Given this list of marker genes VPS11, INPP5E, LYST, PDE4DIP, ECE2, GRIK5, PHACTR4, NAA10, TAF4B, SLC9A7, TRAF2, UCK2, UBXN7, HSPE1, ARSA, APOBEC3B, TTPA, HOMER3, PRKAR1B, PEX6, CEBPE, POLR2H, OGT, RAB32, TUG1, GRAMD4, CALCR, BST1, GTF2H3, TPM2, TSPO, SLC22A4, PRLR, ATP6V0B, BRD8, PMS2P3, TKT, VAT1, KIF2A, ATF2, GPR3 (G protein-coupled receptor 3), GABARAP, WT1-AS, HARS2, AZU1, BCAT1, ATF6B, HADH, TIA1 (TIA1 cytotoxic granule associated RNA binding protein), XPO1, ZYX, APLP2, GPR182, GTF2F2, TLL1, OVOL2, TTC22, TAF1, ENSA, HNF4A, NPC2, RENBP, NFKBIA, VDAC1, SLC25A4, MED21, KAT2A, INPP5F, TBCE (tubulin folding cofactor E), EED, CLIP2, PREPL, WSB2, DMXL2, ANP32E, LUZP1 (leucine zipper protein 1), PRKD1, HMGCS1, CDK6, ADNP, RARB, PGD, CRYZ, DRC3 (NCBI Gene Id 83450), KAT6A, DDHD2, VASP, NUMB, STAU2 (staufen double-stranded RNA binding protein 2), LBR, DENND5A, ORC5, PRPF4, STX11, CEP68, TYMP, LEPR, COL3A1, PMS1, UBE2D1 (ubiquitin conjugating enzyme E2 D1), CA11, TIAL1, GNG12, CORO2A, TAOK3, ZNF271P, APPBP2, GTF2IRD2, MIR22HG, PTP4A2 (protein tyrosine phosphatase 4A2), BTAF1, SLC10A3, ADAM17, ENPP1, TNFRSF17, CD14, RBM34, NACC2, NME1, HNRNPD, PIK3R3, RRAD, CD68, here is a description of the gene set: from publication Yagi T, Morimoto A, Eguchi M, Hibi S, Sako M, Ishii E, Mizutani S, Imashuku S, Ohki M, Ichikawa H (PMID 12738660) Human Gene Set: YAGI_AML_SURVIVAL Most patients with acute myeloid leukemia (AML) enter complete remission (CR) after treatment with chemotherapy, but a large number of them experience relapse with resistant disease. To identify genes that are associated with their prognoses, we analyzed gene expression in 54 pediatric patients with AML using an oligonucleotide microarray that contained 12 566 probe sets. A supervised approach using the Student t test selected a prognostic set of genes, some of which are associated with the regulation of cell cycle and apoptosis. Most of these genes had not previously been reported to be associated with prognosis and were not correlated with morphologically classified French-American-British (FAB) subtypes or with karyotypes. These results indicate the existence of prognosis-associated genes that are independent of cell lineage and cytogenetic abnormalities, and they can provide therapeutic direction for individual risk-adapted therapy for pediatric AML patients. studied in species Homo sapiens Genes differentially expressed in pediatric AML (acute myeloid leukemia) samples from patients with good survival (>3 years without relapse) compared to those with poor survival (relapsed within one year after treatment).